Given this list of marker genes Ppm1a (protein phosphatase 1A, magnesium dependent, alpha isoform), Cab39, Rraga, Mlst8, Rheb, Rragb, Cab39l, Akt1, Strada, Eif4g1, Tsc1, Stradb, Lamtor4, Rps6kb1, Rps6, Rragd, Prkaa2, Eif4b, Rptor, Fkbp1a, Mtor, Prkag3, Prkab1, Eif4ebp1, Prkag1, Lamtor1, Lamtor3, Ywhab, Stk11, Lamtor2, Rragc, Prkag2, Akt2, Eif4e, Lamtor5, Prkaa1, Akt1s1, Eef2k, Prkab2, Slc38a9, Tsc2, here is a description of the gene set: Mouse Gene Set: REACTOME_MTOR_SIGNALLING studied in species Mus musculus MTOR signalling